The following is a description of a gene set: Human Gene Set: GSE45365_WT_VS_IFNAR_KO_BCELL_MCMV_INFECTION_UP species: Homo sapiens Genes up-regulated in CD8 T cells: control versus primary acute viral infection. Murine Cytomegalovirus (MCMV) infection leads to early activation of various immune cells, including B and T lymphocytes, before the actual initiation of antigen-specific adaptive immunity. This activation is partly driven by innate cytokines, including type I interferon (IFN), which are induced early after infection. The objective of this study was to address the role of type I IFN in shaping early/innate B and T cell responses to a primary acute viral infection. In order to decipher the specific impact of IFN-I on cell subsets, we performed a genome-wide expression analysis on WT splenic B and CD8 T lymphocytes isolated from C57BL/6 mixed bone marrow chimera mice. This study complements series GSE39555, which focused on early responses of NK cells and of the two subsets of conventional dendritic cells., and this is the list of marker genes: FGF7, OPHN1, ZNF624, SYT1, COLCA1, ZNF518A, MOAP1, CDK13, CXADR, DHX9, DDX59, RECK, RAB3GAP2 (RAB3 GTPase activating non-catalytic protein subunit 2), SLC16A4, ABHD18, NUMBL, MYO1C, NLN (NCBI Gene Id 57486), FGF13-AS1, HEATR5B (NCBI Gene Id 54497), MDM1, YTHDF3, DSPP, PDE4C, ARHGAP11A (Rho GTPase activating protein 11A), PHIP, PON1, ANKLE1, DLGAP4, ALCAM, TMEM241 (NCBI Gene Id 85019), TMEM212 (NCBI Gene Id 389177), TPR, ZNF763, SUZ12P1, ALMS1, ZNF280D, TMEM167B, CMBL, USP34, CDC40, ADH4, AADAC, NUMA1, BRCA1, KIF23, XRCC2, LINC01426, MPPED2, ZMAT1, ZNF160, ETS2, WDPCP, MTMR9, MKRN2, VPS33A, ENSG00000291101, RASEF, SLC35E1, TMEM232, GOLGB1, SPATA6, FAM106A, HAUS2, CORO2B, MERTK, DNAH3, ZNF721, CDC14C, ABHD11, WDR35, TTC38, HYMAI, PHACTR2-AS1, BCLAF1 (BCL2 associated transcription factor 1), RHOBTB2 (NCBI Gene Id 23221), PRR11, CSKMT, HDHD2 (haloacid dehalogenase like hydrolase domain containing 2), MYO15B, WASHC4, COA8, B3GAT2, SLC25A14, SPDYE1, RAMP2-AS1, ITSN2, SCN11A, FAM161B, DLD, ZP1, ACKR3, LRRFIP1, CALM2, OCIAD1, KRTAP2-4, VPS35, RERGL, ZNF837, SLC6A16, LOXL4, SYF2, DNTTIP2, DIP2A, TEX26, DNAJB7, GABPB1-IT1, UBQLN4, TRIM49, XRCC1, ZNF547, CHD8, SCN1A, GAPT, C11orf97, TPT1-AS1, PGF, GLIDR, LRRC69, ANKRD30BP2, PHF19, FAM98C, CORO7, KIR3DS1, C8orf34, ZC3H7B, DISC1, POTEM, DYNC1I2, TELO2, MICU2, SCD5 (stearoyl-CoA desaturase 5), LINC00899, ADAM33, MEIOC, TSPAN8, TSR3, CCDC152, ZNF430, PLAA, ARNT, ARHGAP29, DDX5, DMTF1, DOCK11, ZNF252P, RAMAC, NEK2-DT (NEK2 divergent transcript), ZDHHC2, ZNF611, TSR1 (NCBI Gene Id 55720, TSR1 ribosome maturation factor), SUPT7L, PCM1, UGT2B15, ATF7IP, RASA1, QNG1, TNC, HMCN1, RRP12, ELOVL2-AS1, CYP4A22, U2SURP, ORC1, ZNF318, BTBD3, ZNF252P-AS1, CDCA8, LINC00265, LTN1, ARL16, ARAP2, UACA (uveal autoantigen with coiled-coil domains and ankyrin repeats), ZNF44, FGFR1, LINC01242, ATP8B1, SYCP1, SLC25A16, ZNF492, NNMT, GALNT1, FBXW12, NR1H2, OR51B4